The following is a description of a gene set: Any process that decreases the rate, frequency, or extent of protein tyrosine kinase activity. studied in species Homo sapiens Human Gene Set: GOBP_NEGATIVE_REGULATION_OF_PROTEIN_TYROSINE_KINASE_ACTIVITY, and this is the list of marker genes: SRCIN1, MVP, SOCS4, SOCS5, ZFYVE28, VPS25 (vacuolar protein sorting 25 homolog), SNX6, PTK6, GPRC5A, TSG101, ZGPAT, ERRFI1, CHMP6